Given this list of marker genes TNFRSF11B, SLC9A1, AIMP2, ATP6V1G1, IFNB1, TRPV5, CTSK, TNFRSF11A, IFNAR1, SPP1, GPR68, TNFSF11, PDGFB, MAPK8, ITGB3, ACP5, here is a description of the gene set: Osteoclast signaling Human Gene Set: WP_OSTEOCLAST_SIGNALING studied in species Homo sapiens